The following is a description of a gene set: studied in species Homo sapiens Abnormal CSF metabolite concentration Any deviation from the normal range of concentration of a metabolite in the cerebrospinal fluid. Human Gene Set: HP_ABNORMAL_CSF_METABOLITE_CONCENTRATION, and this is the list of marker genes: MT-TL1, TICAM1, NDUFA1, ASPA, NDUFA8, ALDH5A1, LSM11, MT-TH (NCBI Gene Id 4564), NDUFAF1, NGLY1, DLAT, GFM2, TPK1, NDUFS8, TMEM126B, NDUFS2, NDUFB11, GCH1, ATP5PO, TLR3, MT-ND5, SURF1, ALDH4A1, D2HGDH, MT-CO3, NDUFS3, SUCLA2, COX20, STAT2, MT-TV, NDUFA6, DPYS (dihydropyrimidinase), MT-TF, PIGA, SCO2, BOLA3, AIFM1, CLPB, TXN2, RNASEH2A, IMPDH2, SLC25A4, NR4A2, MT-TQ, NDUFV1, NDUFV2, DLD, CYP27A1, MT-ND1, FOXRED1, COX10, DNM1L, MT-ND2, TIMM50, PNPO, COX14, PDHA1, ATPAF2, MT-TW, MT-CO1, NDUFB8 (NCBI Gene Id 4714), NDUFAF8, GLUL, LONP1, NDUFS7 (NCBI Gene Id 4727), FARS2, NDUFS1, MTFMT, TSPOAP1, SLC13A3, PSAT1, HTRA2, MT-ND3, NDUFAF2, MT-ATP6, TRAF3, SLC39A8 (NCBI Gene Id 64116), MT-TN, TIMMDC1, COA8, RRM2B (ribonucleotide reductase regulatory TP53 inducible subunit M2B), DHFR, TRAPPC12, COX4I1, UNC93B1, RMND1, AMT, SLC31A1, ECHS1, UQCC3, LRPPRC, COX6B1, RARS2, PDHX, RNASEH2B, TRMT10C, TH, MDH2, MT-ND6 (NCBI Gene Id 4541), NDUFA4, NUBPL, AASS, SLC25A1, SAMHD1, NDUFAF4, LYRM7, NDUFAF5, SPTBN1, KARS1 (lysyl-tRNA synthetase 1), GLRX5, NAXE, NADK2, RNASEH2C, NDUFA12, SLC2A1, MECP2, GLYCTK, HPDL, PNPT1, DDC, COQ8A (NCBI Gene Id 56997), RNU7-1, UPB1, NDUFB3, MRPS34, MT-TS2, MT-TK, NDUFS6, ASL, MT-ND4, BCKDK, SLC6A3, TREX1, MPV17, ADK, UQCC2, TBK1, PTS, NDUFB10, NDUFS4, HSD17B10, NDUFA10, COX8A, HMBS, DARS2, NFU1, NDUFB9, NDUFAF3, LYRM4, OPA1, GFM1, NARS2, IBA57, PET100, PET117, SLC25A19, PNPLA8, MT-CO2, COX11, IFIH1, PEX12, ERCC6, ADAR, RNU4-2, GCSH, RPIA, SUCLG1, NDUFA11